Given this list of marker genes Cfb, Il33, Ms4a6d, Dsc2, Nectin4, Pfkfb3, Apaf1, Cxcl5, Thbd, Amer2, Hbb-bt, Spink12, Slfn10-ps, Cd14, Stxbp5l, Stom, Timp1, Dmkn, Pf4, Iigp1 (interferon inducible GTPase 1), Slpi, Ccl5, Reg3b, Cldn1, Sprr2f, Cfd, Sbno2 (NCBI Gene Id 216163), Cxcl3, Slitrk1, Slfn3 (NCBI Gene Id 20557), Inhba (inhibin beta-A), Tifa, Hp, Wfdc17, Pirb, Arg1, S100a8, Rtn1, Ly6c1, Cstdc6 (NCBI Gene Id 100038854), Ttc9, Saa3, Arrdc4, Mup10, Lrg1, C3, Plat, Cd38, Celsr1, Tgm1, Slfn9, Fzd1, Tac1, Frem1, Ptx3, Mup1, Mfsd2a, 5330439B14Rik, Slc25a30, Olr1, Retnla, Aldh1l1, Ccl8, Oxtr, Wfdc18, Myhas, S100a9, Sting1, Ncmap, Hba-a1, here is a description of the gene set: from publication Zheng Y, Valdez PA, Danilenko DM, Hu Y, Sa SM, Gong Q, Abbas AR, Modrusan Z, Ghilardi N, de Sauvage FJ, Ouyang W (PMID 18264109) Mouse Gene Set: ZHENG_IL22_SIGNALING_UP studied in species Mus musculus Genes up-regulated in ex-vivo colonic tissue after treatment with IL22. Infections by attaching and effacing (A/E) bacterial pathogens, such as Escherichia coli O157:H7, pose a serious threat to public health. Using a mouse A/E pathogen, Citrobacter rodentium, we show that interleukin-22 (IL-22) has a crucial role in the early phase of host defense against C. rodentium. Infection of IL-22 knockout mice results in increased intestinal epithelial damage, systemic bacterial burden and mortality. We also find that IL-23 is required for the early induction of IL-22 during C. rodentium infection, and adaptive immunity is not essential for the protective role of IL-22 in this model. Instead, IL-22 is required for the direct induction of the Reg family of antimicrobial proteins, including RegIIIbeta and RegIIIgamma, in colonic epithelial cells. Exogenous mouse or human RegIIIgamma substantially improves survival of IL-22 knockout mice after C. rodentium infection. Together, our data identify a new innate immune function for IL-22 in regulating early defense mechanisms against A/E bacterial pathogens.